Given this list of marker genes ACADS, HADHB, ECHS1, HADH, HADHA, here is a description of the gene set: Beta oxidation of hexanoyl-CoA to butanoyl-CoA species: Homo sapiens Human Gene Set: REACTOME_BETA_OXIDATION_OF_HEXANOYL_COA_TO_BUTANOYL_COA